Given this list of marker genes SMARCAL1, POM121, UNC45A, FNDC3A, PHC1, CCDC61, MARCHF7, CORO7, PLEKHA2, CACNA2D2, ING5 (NCBI Gene Id 84289), ATP6V1H, ARHGEF2, ZEB1, NCKAP1L, RAD50 (RAD50 double strand break repair protein), C15orf48, PAFAH1B1 (platelet activating factor acetylhydrolase 1b regulatory subunit 1), DNAJB5 (NCBI Gene Id 25822), UBE2H, COPG2, ARHGAP25, GAPVD1, TIMP1, BIRC3, ZNF251, STX2, KLF10 (NCBI Gene Id 7071), KLF9, AHCTF1, POLR2B, PLEKHF2, ASAH1, BLOC1S6, KANSL3, PAK1IP1, ZKSCAN1, DDR1, ZMYM2, COG6, CPNE3, FNBP1L, ZNF655, DYNC1I2, ECT2, GNA13, WDR81, CTNNB1, CASD1, INTS1, SVIL, INTS4, TIAM1, NPAT, TGFBR1, PBX3, ARID4B, PTBP3, RTF1, ZNF451, CELA1, BDH2, FBXW11, CEP85, SPRED1, GSN, MSL1, HNMT, FBXO2, RNF141, ELK3, CDC16, THAP12, MAPK9 (mitogen-activated protein kinase 9), TSPO, HTT, PRPS1, CD38, ARL8B, VCPIP1, ALPK2, CD86, MGAT5, NUP153, MAF, MAP3K4, PAIP1, GPD2, UBR3, ATOSA, TMEM30A, FKTN, RAB3GAP2, IL1RN, ID1, SIAH1, PLSCR3, SERINC5, SMC6, MAGED2, WDR26, PXN (paxillin), UBASH3B, CDS2 (NCBI Gene Id 96708), STX1A, RSPRY1, RORA, TMX4, CTTN, NOTCH1, ATF1, TNIP2, RAB18, PRKD3, POFUT1, ADAM9, CYRIA, GAB2, SEPSECS, SLC39A8, ACVR1, RNF215, TSC22D1, ALDH3A2, KAT2B, EAF2, BCR, ARHGAP39, GCNT2, CRK, CENPE, SLK, MTMR7, GPATCH8, SEMA7A, EEIG2, NAB1, IKZF3, TENT5C, EDEM3, TACC2, BCL11B, TNK2, SGK1 (serum/glucocorticoid regulated kinase 1), PLCG1, BMPR2, PRR13, ARMCX4, PTCH1, TUBGCP5, CNTROB, PIK3R1, HEMGN, OSBPL3, SPART (NCBI Gene Id 23111), IQGAP1, EIF2AK3, P4HA1, IFT140, WASF1, BICD2, ARF1, CSNK2A2, MGAT4A (alpha-1,3-mannosyl-glycoprotein 4-beta-N-acetylglucosaminyltransferase A), NISCH, NSD3, KRAS, MYB, NT5E, CTSW, TAGAP, BMP2K, CBFB, ZDHHC18, GCLC, PDPK1, ITGB2, TOX2, SEC24D, CYSLTR1, S1PR3, REST, SBK1, TNFRSF13B, KCTD14, CSGALNACT1, PGF, XRN2, NFKB1, FNIP2, TSPAN13, SNIP1, MTSS1, GRN, ATXN10, LRRC39, TIGD2, HERC4, GFPT2, TMED2, here is a description of the gene set: studied in species Homo sapiens TGF-beta3 produced by developing Th17 cells induces highly pathogenic T cells that are functionally and molecularly distinct from TGF-beta1-induced Th17 cells. The microarray data represent a distinct molecular signature for pathogenic versus non-pathogenic Th17 cells. Human Gene Set: GSE39820_TGFBETA1_IL6_VS_TGFBETA1_IL6_IL23A_TREATED_CD4_TCELL_UP from publication Lee Y, Awasthi A, Yosef N, Quintana FJ, Xiao S, Peters A, Wu C, Kleinewietfeld M, Kunder S, Hafler DA, Sobel RA, Regev A, Kuchroo VK (PMID 22961052) Genes up-regulated in comparison of CD4 T cells treated with TGFB1 and IL6 versus those treated with TGFB1, IL6 and IL23A.